The following is a description of a gene set: species: Homo sapiens Human Gene Set: FAN_EMBRYONIC_CTX_BRAIN_ENDOTHELIAL_1 from publication Fan X, Dong J, Zhong S, Wei Y, Wu Q, Yan L, Yong J, Sun L, Wang X, Zhao Y, Wang W, Yan J, Wang X, Qiao J, Tang F (PMID 29867213), and this is the list of marker genes: LXN, IMPDH1 (inosine monophosphate dehydrogenase 1), RBP1, CALCRL, SLC16A14, SERPINH1, MT1X, GJA1, ANXA1, MEGF6, ARHGEF15, IGFBP2, PLS3, SMAGP, PARVA, PKP4, VWA1, BBS9, ABHD17A, FRY, STX3 (syntaxin 3), AFDN, LEF1, CAVIN2, MX1, ADM, ACTN4, CCN1 (cellular communication network factor 1), ID1, CHST12, DGAT1, STRA6, NPDC1, TIMP1, CAVIN3, APOL4 (NCBI Gene Id 80832), MYORG, SULT1C4, FLT4, APCDD1, HOPX, MLEC, CD82 (CD82 molecule), MICALL2, PRSS12, TSC22D1, GPCPD1, ARAP3 (ArfGAP with RhoGAP domain, ankyrin repeat and PH domain 3), NID1, CLIC5, FLNB, SLC31A1, PROCR, CLIC4, SLC7A8, SMTN, SLC2A1, CAV1, S1PR1, SOX18, DPEP1 (dipeptidase 1), IGFBP4, MAGED2, NIBAN2, BHLHE40, RAPGEF5, ARL2, CD27, JAM2, CD151, INSR, IGF2BP2, SHC2, TDRP, LIMS2, TRIM16, LAMB2, SAMM50, LIFR, PTPRG, PDLIM2, FAM43A, RPS6KA2, SORBS3, APOLD1, IL32, MAP4K2, GADD45A, PREX2, PLLP, THSD1, GPD1L, ALPL, CDC42EP1, STARD4-AS1, SLC3A2, TCF4, RGCC, COX7A1, SPOCK2, SESTD1, ADGRL2, COL5A2, CRIP2, TMEM50B, EBF1, CAVIN1, KDR, PTP4A3 (NCBI Gene Id 11156), EFR3B, LAMB1, SLC16A1, AIF1L, SNTB2, ACE, DOCK9, ARHGAP18, BLCAP, PAM, CPD, OCLN, FZD4, CCDC186, S100A13 (NCBI Gene Id 6284), SLCO2A1, FXYD5, CYB5R3, PRCP, HYAL2, ELN (NCBI Gene Id 2006), MFSD2A, HAPLN3, GBP4, TCN2, RAI14, DIPK2B, MAGI1, NPIPB3, PODXL, PRKCH, GALNT18, ZDHHC9, SLC1A4, RELL1, IFNAR2, PLXND1, GRPEL2, IFIT1, CLEC2B, MGST2 (microsomal glutathione S-transferase 2), ACVR1, LDLRAD3, CAV2, MFAP2, TGM2, HMCN1, CLIC1, PELO, S100A10, LAMA5, CYYR1, TTN, KLF4 (NCBI Gene Id 9314), PPFIBP1, CLDN5 (NCBI Gene Id 7122), HES1, ITGA5, SPTBN1, SOX7, CD200, BEX3, MMP28, SLC2A3, TUSC3, PALMD, TMEM88, HSPA12B, RGS3, FOXQ1, GGT5, TMEM204, TLE1, ITGA6, ENG, CCDC141, EMCN, VIM, APLNR, PLK2 (polo like kinase 2), PLAAT3, CDH11, ACVRL1, CA4, PXN, SMAD1, ZIC2, ESAM, JCAD, SH2D3C, WWTR1, TAGLN2, NKD2, STXBP1, DOK4, UNC5B, ZIC3, TPM4, LMCD1, TM4SF18, ANGPT2, FAM171A1 (family with sequence similarity 171 member A1), MMRN2, PRXL2B, CLEC14A, NID2, PTPRM, LY6E, ID3, LAPTM4B, CEP112, MAOA, BST2, SPARCL1, CSRP1, PDXK, MALT1, DNAJC1, HDAC7, FKBP1A, DLL4, RHOJ, LSR, MOB2, NQO1, MDK, CDA, BCL6B, FN1, RASGRP3, PXDN, ECE1, PDE4B, FSTL1 (NCBI Gene Id 65385), DACH1, ITM2A, IFI44, ADGRL4, LMO2, CTHRC1, CARHSP1, PCBD1, LRP8, PPIC, CLTB, SLC52A2, SPINK8, ST6GALNAC1, BMPR2, KITLG, NOTCH1, AFAP1L2, PIK3R6, CDH5, COL6A2, LRRC17, ABLIM1, SVIL, EFNA1, AFAP1L1, MMP25, FZD6, RFTN2, JUP, TTYH2, ISG15, RUNDC3B, KANK3, ERG, ECSCR, PTPRB, NES, FOXC1, FLT1, ZNF366, IGF1R, TBX3, GDPD5, TMTC4, SLC5A6, SEMA6A, GNG11, TM4SF1 (NCBI Gene Id 9004), RAPGEF4, COBLL1, DSTN, BSG, IFI44L, RASIP1, PFKL, AHNAK, MYLK2, DNPEP, PROM1, DLC1, MT1E, OCIAD2, MT2A, TSPAN5, UTRN, NEIL1, ECM1, MYCT1, SLC38A5, TNS2, FOXF1, TMEM45B, MSRB3, ABLIM3, TJP1, EPAS1, SLC39A10, HEY1, MANSC1, OXR1, NOS3, EGFL7, MYO1B, MYO10, MYO6, IFI27, CETP, SERINC5, SOX17, SLC39A8, CA2, CAPN2, PLEKHG1, SRARP, CDC42EP4, IGFBP7, ADGRF5, SORBS1, SVIP, NHERF2, PCAT19, VWF, CD34, MT1F, CD320 (NCBI Gene Id 51293), RRAGA, ROBO4, CD9, HIP1R, FHL3, HEG1, EDN1, PLCB4, VAMP5, CDH6, SMG1P2, IFITM1, NOSTRIN, SLC14A1, SLC38A3, PPM1H, BCR, C12orf57, TFRC, SLC7A1, TSPAN6, LRATD1, FKBP9, GIMAP7, EMP2, ARHGAP29, IFI35, KIAA1671, PHLDB1, NOTCH4, ATP10A, C1orf54, S100A16, SPARC, ESYT2, SEMA3G, MATN2, NAMPT, ITPR3, AXIN2 (NCBI Gene Id 8313), PCDH12, TUBB6 (tubulin beta 6 class V), SLC16A2, PECAM1, CGNL1, VWA2, KLHL5, PARP12, SCARB1, CYB5A (cytochrome b5 type A), PGRMC1, ADCY4, HPCAL1, CNN3, LAMA4, CSRP2, DEGS2, TIE1, PRXL2A, RHOC, LAMC1, DIPK1B, HID1 (HID1 domain containing), ABCB1, PPA1, DSP, TSPAN9, CDH2, NECTIN2, CD93, USHBP1, POMP, TEK, IFITM3, IFI6, MYH10, C1orf115, WFS1, MECOM, ADAM15, LAPTM4A, SLC7A11, FOXF2, CLEC3B, RAMP2, YES1, SLCO1A2, PON2 (paraoxonase 2), QPCT, SLC7A5 (solute carrier family 7 member 5)